Given this list of marker genes Kcna5, Kcnd3, Agt, Scn3b, Gjc1, Isl1, Slc9a1, Kcnn2, Dsc2, Flna, Scn5a, Mir208a, Kcnq1, Kcne2, Kcnj2, Ace2, Hrc, Pde4d, Cacna1c, Src, Scn4b, Kcne3, Sri, Tbx5, Gja5, Ace, Dsp (desmoplakin), Irx3, Zmpste24, Cxadr, Nup155, Kcne4, Gja1, Trpm4, Kcnh2, Tnni3k, Tbx18, Cav1, Hcn4, Pkp2, Cacna1d, Cacnb2, Sptbn4, Kcnj5, Slc4a3, Tmem65, Nkx2-5, Kcne5, Scn2b, Slc8a1, Akap9, Abcc9, Bin1, Kcne1, Pln, Mef2a, Cacna2d1, Rangrf, Jup, Ryr2, Ehd3, Dsg2, Scn1b, Kcnh6, Gjd3, Ank2, Scn10a, Ctnna3, here is a description of the gene set: Mouse Gene Set: GOBP_CARDIAC_CONDUCTION Transfer of an organized electrical impulse across the heart to coordinate the contraction of cardiac muscles. The process begins with generation of an action potential (in the sinoatrial node (SA) in humans) and ends with a change in the rate, frequency, or extent of the contraction of the heart muscles. studied in species Mus musculus